The following is a description of a gene set: Any process that modulates the frequency, rate or extent of the chemical reactions and pathways involving amides. Mouse Gene Set: GOBP_REGULATION_OF_AMIDE_METABOLIC_PROCESS studied in species Mus musculus, and this is the list of marker genes: Trp53, Gsk3a, Clu, Nfe2l2, Abca2, Rock1, Gga3, Rtn4, Enpp7, Ifngr1, Pdk2, Tigar, Ifng, Prnp, Csnk1e, Spon1, Rela, Efna1, Prkcd, Ccn1, Casp3, Mlst8, Epha4, Rtn2, Nr1h4, Bckdk, Sphk1, Rock2, Sorl1, Tmed10-ps, Ormdl2, Pla2g6, Ormdl1, Tnf, Rtn1, Zfp750, Pgk1, Aldob, Pdk4, Rack1, Samd8, Apoe, Igf1, Hap1, Sphk2, Tpk1, Abca7, Pin1 (NCBI Gene Id 67670), Slc7a11, Lrrtm3, Hsd11b1 (hydroxysteroid 11-beta dehydrogenase 1), Chrna7, Sirt3, Snca, Pdk1, Gsap, Abcg1, Pin1rt1, Bin1, Tmed10, Tnfrsf1a, Eif2ak3, Slc2a13, Sp1, Rtn3, Nsmaf, Pdk3, Picalm, Rps23rg1, Rptor, Ntrk2, Eed, Paqr4, Smpd3, Ormdl3, Mtor